The following is a description of a gene set: species: Mus musculus Reactome Pathway: Regulation of NF-kappa B signaling electronically inferred by orthology from the curated human pathway This event has been computationally inferred from an event that has been demonstrated in another species.<p>The inference is based on the homology mapping from PANTHER. Briefly, reactions for which all involved PhysicalEntities (in input, output and catalyst) have a mapped orthologue/paralogue (for complexes at least 75% of components must have a mapping) are inferred to the other species. part of: TAK1-dependent IKK and NF-kappa-B activation  , and this is the list of marker genes: Ubb, Rps27a, Nlrx1, Ikbkb (inhibitor of kappaB kinase beta), Lrrc14, Nlrc5, Casp8